The following is a description of a gene set: from publication Bauer AK, Rondini EA, Hummel KA, Degraff LM, Walker C, Jedlicka AE, Kleeberger SR (PMID 21543283) species: Homo sapiens We previously identified toll-like receptor 4 (Tlr4) as a candidate gene responsible for ozone (O3)-induced pulmonary hyperpermeability and inflammation. The objective of this study was to determine the mechanism through which TLR4 modulates O3-induced pulmonary responses and to utilize transcriptomics to determine TLR4 effector molecules. C3H/HeJ (HeJ; Tlr4 mutant) and C3H/HeOuJ (OuJ; Tlr4 normal), mice were exposed continuously to 0.3 ppm O3 or filtered air for 6, 24, 48 or 72 hr. Affymetrix Mouse430A_MOE gene arrays were used to analyze lung homogenates from HeJ and OuJ mice followed using a bioinformatic analysis. Inflammation was assessed by bronchoalveolar lavage and molecular analysis by ELISA, immunoblotting, and transcription factor activity. TLR4 signals through both the MYD88-dependent and independent pathways in OuJ mice, which involves MAP kinase activation, NF-kappaB, AP-1, and KC. Microarray analyses identifiedTLR4 responsive genes for strain and time in OuJ versus HeJ mice (p<0.05). One significantly upregulated cluster of genes in OuJ were the heat shock proteins (Hspa1b; Hsp70), Hsp90ab1). Furthermore, O3-induced expression of HSP70 protein was increased in OuJ compared to HeJ mice following 24-48 h O3. Moreover, BAL polymorphonuclear leukocytes (PMN) and total protein were significantly reduced in response to O3 in Hspa1a/Hspa1btm1Dix (Hsp70-/-) compared to Hsp70+/+ mice (p<0.05). TLR4 signaling (MYD88-dependent), ERK1/2, AP-1 activity, and KC protein content were also significantly reduced after O3 exposure in Hsp70-/- compared to Hsp70+/+ mice (p<0.05). These studies suggest that HSP70 is involved in the regulation of O3-induced lung inflammation through the TLR4 pathway and provide evidence that HSP70 is an endogenous in vivo TLR4 ligand. Human Gene Set: GSE20715_WT_VS_TLR4_KO_24H_OZONE_LUNG_UP Genes up-regulated in comparison of lung tissue from wild type mice subjected to ozone for 24 h versus that from TLR4 deficient mice subjected to ozone for 24 h., and this is the list of marker genes: HACD1, PITRM1, PDXK, ITGA8, PIGU, USP2, COL13A1, NR2F1, OSBPL6, BHLHE40, LHX2, SLC25A33, EFHD1, CA8, PNKD, MTO1, ATP2B2, LRP2, AAMDC, SLC66A3, NME2, COL1A2, PHOSPHO1, UQCC2, SVEP1, DDR1, CTSS, B3GNT2, SEC62, SPICE1, RPE, ERAP1, RPL11, STEAP3, EPHX1, LGALS1, TYROBP, SRPX2, IPP, RORC, P2RY14 (NCBI Gene Id 9934), ACSL1, GBE1, IQGAP1, NOTUM, FANCL, IL1RL2, GGPS1, ART4, RERE, SPG11, ALAS1, PPP3R1, PILRB, RAB18, COPZ2, PRXL2B, ICAM1, TOR1AIP2, ST7, ANGPTL2, TCOF1, SMAD7, PILRA, ARMCX3, MAPK10, C1QTNF12, SOX9, CPN1, CRISPLD1, RHOA, FBLN5, PARP3, SLC7A10, RBP1, ANKH, NAA60, TGFBR2, MEOX2, HSD11B1, PRIM1, LAMA3, ABCG1, NOL3, PTGFR, BMP4, RBM4, BCAP31, CXCL14, CRYAB, AVIL, PINX1, P4HB, MX1, TMT1A, NR1D2, KCNK10, PCYOX1, DOCK7, ARMT1, OLFML3, SLC1A5, SEPTIN2, DNAJC1, TPST1, TRAPPC13, RRM2B, CCN5, ALCAM, FIG4, PPP1R3F, CYBB, ACSM1, HUNK (hormonally up-regulated Neu-associated kinase), NFE2L2, HS2ST1, GREM2, WRN, CHRNB2, EMP2, ASPN, MFAP4, FABP1, SLC16A7, MLH3, GNAI1, TMTC4, COP1, LRAT, ONECUT3, TSPAN4, TSPAN12, RRAGC, TMEM119, PER3, MEFV, RPS27L, TLR2, LRRK1, RPL7L1, JKAMP, EPB41L3, RLN1, CCDC82, SNAI2, CLVS1 (clavesin 1), PNLIP, CHCHD1, ABCG4, DCLRE1A, PCDHB14 (NCBI Gene Id 56122), PDGFA, KPNA4, FAM76A, MUC20, PLCE1, ACP3, PLXNC1, MAGT1, DNM1, GNPDA2, ANO1, PAIP2, SEH1L, SLC12A6, CIAO2B, ITGAL, PDCL, CHRNA5, VPS41, PLA2R1, NANP, RCN3, AGPAT5, CNTN6, PER2, COL4A5, ADH1C, SLC25A24, PDIA3, SSPN, SLC5A7, LIPA, AP3M2, FBXO3, SLC35B1, IVD, SLC44A3, CAVIN2, PDC, APBB1IP, NCAPG2, GDF10, EMC7 (NCBI Gene Id 56851), GRP, PON3, HLF, CD302, POPDC3, GFAP (NCBI Gene Id 2670)